The following is a description of a gene set: species: Mus musculus Genes up-regulated in testis tissue upon knockout of CTCFL. from publication Suzuki T, Kosaka-Suzuki N, Pack S, Shin DM, Yoon J, Abdullaev Z, Pugacheva E, Morse HC 3rd, Loukinov D, Lobanenkov V (PMID 20231363) Human Gene Set: SUZUKI_CTCFL_TARGETS_UP Previously, it was shown that the CTCF paralogous gene, BORIS (brother of the regulator of imprinted sites) is expressed in male germ cells, but its function in spermatogenesis has not been defined. To develop an understanding of the functional activities of BORIS, we generated BORIS knockout (KO) mice. Mice homozygous for the null allele had a defect in spermatogenesis that resulted in small testes associated with increased cell death. The defect was evident as early as postnatal day 21 and was manifested by delayed production of haploid cells. By gene expression profiling, we found that transcript levels for Gal3st1 (also known as cerebroside sulfotransferase), known to play a crucial role in meiosis, were dramatically reduced in BORIS KO testes. We found that CST is expressed in testis as a novel testis-specific isoform, CST form F(TS), that has a short exon 1f. We showed that BORIS bound to and activated the promoter of CST form F(TS). Mutation of the BORIS binding site in the promoter reduced the ability of BORIS to activate the promoter. These findings define transcriptional regulation of CST expression as a critical role for BORIS in spermatogenesis., and this is the list of marker genes: MDN1, MYF6, CKM, TFF1, SEPTIN1, UBP1, DBNDD2, CAMK2D, ZNF704, PPY, NOP58 (NCBI Gene Id 51602), ADK